Given this list of marker genes Igsf3, Tmem255a, Ptprr, Acta2 (actin alpha 2, smooth muscle, aorta), Rln1, Syt1, Tcam1, Nckap5 (NCBI Gene Id 380609), Susd4, Ank3, Insyn2b, Igf1, Zeb2 (NCBI Gene Id 319891), Col4a4, Scml4, Tal2, Htr2a, Syt3, Col4a3, Plat, Ucp1, Cfap65, Nol3, Kcnj2, Npy2r (NCBI Gene Id 18167), Kcnmb2, Mchr1, Caly, Gm5148, AI593442, Rhoj, Esr2, Col1a1, Kcna4, Ypel4, here is a description of the gene set: Genes with intermediate-CpG-density promoters (ICP) bearing the bivalent trimethylation marks at H3K4 (H3K4me3) and H3K27 (H3K27me3) in MCV6 cells (embryonic fibroblasts trapped in a differentiated state). Mouse Gene Set: MIKKELSEN_MCV6_ICP_WITH_H3K4ME3_AND_H3K27ME3 from publication Mikkelsen TS, Hanna J, Zhang X, Ku M, Wernig M, Schorderet P, Bernstein BE, Jaenisch R, Lander ES, Meissner A (PMID 18509334) Somatic cells can be reprogrammed to a pluripotent state through the ectopic expression of defined transcription factors. Understanding the mechanism and kinetics of this transformation may shed light on the nature of developmental potency and suggest strategies with improved efficiency or safety. Here we report an integrative genomic analysis of reprogramming of mouse fibroblasts and B lymphocytes. Lineage-committed cells show a complex response to the ectopic expression involving induction of genes downstream of individual reprogramming factors. Fully reprogrammed cells show gene expression and epigenetic states that are highly similar to embryonic stem cells. In contrast, stable partially reprogrammed cell lines show reactivation of a distinctive subset of stem-cell-related genes, incomplete repression of lineage-specifying transcription factors, and DNA hypermethylation at pluripotency-related loci. These observations suggest that some cells may become trapped in partially reprogrammed states owing to incomplete repression of transcription factors, and that DNA de-methylation is an inefficient step in the transition to pluripotency. We demonstrate that RNA inhibition of transcription factors can facilitate reprogramming, and that treatment with DNA methyltransferase inhibitors can improve the overall efficiency of the reprogramming process. species: Mus musculus